The following is a description of a gene set: part of: Metabolism Reactome Pathway: Metabolism of vitamins and cofactors Vitamins are a diverse group of organic compounds, classified according to their solubility, either fat-soluble or water-soluble, that are either not synthesized or synthesized only in limited amounts by human cells. They are required in small amounts in the diet and have distinct biochemical roles, often as coenzymes (cofactors). The physiological processes dependent on vitamin-requiring reactions include many aspects of intermediary metabolism, vision, bone formation, and blood coagulation, and vitamin deficiencies are associated with a correspondingly diverse and severe group of diseases. species: Homo sapiens, and this is the list of marker genes: LDLRAP1, NT5E, PARP14, AKR1C4, AKR1C1, FLAD1, CTRB2, DHFR, GSTO2 (glutathione S-transferase omega 2), TCN1, FPGS (folylpolyglutamate synthase), SLC5A6, MTHFR, SLC23A1, COQ6, THTPA, APOC3, FOLR2, ACP5, BST1, TTR, MMACHC, RBP2, LRP8, VKORC1, ABCD4, MOCS3, NFS1, RFK, PANK2, AASDHPPT, VKORC1L1, SDC3, MMADHC, SLC19A3, SPR, AMN (amnion associated transmembrane protein), NMRK1, AOX1 (NCBI Gene Id 316), GPC3, COQ8B, BTD, PRSS1, PNPO, ACO1, MTHFD1, SLC22A13, SLC2A1, PRSS3, LRP12, DCAKD, PARP16, CBLIF, TTPA, MCCC1, MMAA, GSTO1, AKT1, PDSS2, MTHFD1L, SLC25A42, NNMT, GPC1, ACACA, AGRN, MOCOS, COQ7 (NCBI Gene Id 51672), PTS, SLC52A1, ABCC1, PARP4, GCHFR (GTP cyclohydrolase I feedback regulator), COQ8A, CD38, ENPP1, BCO2, NUDT8, CYB5R3, GPC5, ALDH1L2, MTHFD2L, COQ2, NOS3, LRAT, SDC2, SLC19A2, HSP90AA1, NADSYN1 (NAD synthetase 1), NMNAT3, TCN2, BCO1, LRP10, HLCS, GPC2, SLC25A19, SLC25A51, SDC4, PPCS, RBP1, APOA2, APOB, SHMT2, PANK4, AKR1C3, GPC4 (glypican 4), CD320, APOA4, SLC2A3, PDXK, ALDH1L1, SLC25A32, PPCDC, RDH11, NUDT12, APOM, SLC23A2, NAPRT, ACACB, VNN2, DHFR2, GCH1, IDH1, APOC2, CUBN, APOE, PARP10, VNN1, NAXE, SDC1, QPRT, CTRB1, LDLR (NCBI Gene Id 3949), MMUT (NCBI Gene Id 4594), NADK2, COQ9, GPIHBP1, LRP1, PDZD11, PANK1, NMRK2, NAXD, UBIAD1, PARP9, SLC25A16, STARD7, ENPP3, MTR, NAMPT, MTHFS, MTHFD2, PARP6, NMNAT1, CYB5A, TPK1, GPHN, LRP2, ENPP2, LPL, MTRR, MCCC2, SLC46A1, PNLIP, FASN (fatty acid synthase), SLC5A8, NADK, COASY, HPDL, SLC52A2, NMNAT2, PC, COQ4, SLC52A3, LMBRD1, PARP8, MOCS2, PDSS1, PLB1, GPC6, PCCB, SLC19A1, COQ5, AKR1B10, MMAB, CLPS, RETSAT, HSPG2, PCCA, APOA1, PANK3, MOCS1, PRKG2, SHMT1, COQ3, RNLS, RBP4, CALM1